Given this list of marker genes HIC1, RNASE10, BOK, RNF133, GADD45GIP1, POGK, ITGA6, APMAP, NAB2, WDHD1, MORN3, MGMT, MRPL11, RASSF7, RBBP8, NR2C2AP, ATP6V1C1, PIK3R2, RNPC3 (RNA binding region (RNP1, RRM) containing 3), GK, ALKBH3, GPR88, VPS25, CMSS1, FKBP3, STC2, HAPSTR1, CBR4, CHST6, B4GALNT1, FURIN, SLC35F3, CHML, ADARB1, THRAP3, RBIS, NDUFC2, HOOK2, PSMC4, DTX3, TFPI2, NDUFA9, COX10, CCT4, TNNT3, DCTN6, WNT8B, SDHAF1, GCNT2, ABRACL, SETD3, UNC13A, CHAMP1 (chromosome alignment maintaining phosphoprotein 1), NPHP1, PTTG1, POMT2, EID1, FAM72A, SGCB, CPD, DUS4L, KCTD14 (potassium channel tetramerization domain containing 14), FBXW8, ZNF490, UTP11, RBP1, MRM3, TRIM11 (tripartite motif containing 11), NDUFA7, IL1R2, CENPC, RNMT, MRI1, CIMIP4, CCDC172, SPEG, METAP1D, HTR5A, SVIP, THOC7, RHOB, EIF4G2, PARVG, MS4A13, UBE2E3, PDK1, ACSL4, UCHL1, ADGRA1, CALCOCO2, HNRNPA3, CCDC136, COX4I1, NRM, KPNA4, LTK, CCDC90B, PCM1, B3GALT6, TMEM14A, ADAM21, TTLL1, KPNB1, TNS1, PDHB, ACTL9, IL10, SRPRA, RPS25, HAT1, TSPYL1, GINS1, KHDRBS1, DNM1L, CARNMT1, MAPK10, UXT, MYBL1, OGDH, PPP2CA, TLK1, MICU2, SLC25A4, FGFR2, SIPA1L1, VPS37D, KCTD7, MDH1, GABRA3, MARCKS, TUBA4A, UBLCP1, MAOB, C1D, PLPP4 (NCBI Gene Id 196051), RBMS2, SEC24A, H2AC25, RGS12, POLR2B, SPAG1, ZNF354A, GABBR1, SFXN5, SLC35F1, OCIAD2, STT3B, MEGF10, POLR1D, GRIA2, TTC39A, NUP54, BCKDK, CUL4A, HNRNPK, SLC25A39, ADTRP, FRYL, ZNF239, SCARB1, ROR2, AFAP1L2, STX1A, CPTP, NAP1L1, B4GALT7, AOPEP (aminopeptidase O (putative)), GPX5, SOD2, COA6, E2F5, CELA1, SNX32, MID1, CH25H, MRPL22, MAPK8, THSD7B, MDM1, GGPS1, CLNS1A, DYNLL2, COX5A, STT3A, ASB3, TBCD, SNORD123, OLFM3, POLR1C, VWA8, POSTN, HNRNPR, B3GALNT1, VPS29, ZNF318, DNPEP, USP38 (ubiquitin specific peptidase 38), TOMM20, SLC9B2, SDC4, here is a description of the gene set: IL-10 or IL-6 stimulation of control 129xC57BL/6 murine bone marrow derived macrophages in the presence of LPS. We used microarrays to detail the global programme of gene expression changes in response to IL-6 or IL-10 stimulation in the presence of lipopolysaccharide. BMDMs were isolated from control, IL-6-/-, and IL-10-/- mice on a 129XBL/6 mixed background mice and differentiated in the presence of CSF-1 for 6-7 days. Cells were scraped and plated in 6 well plates at 2x10e6/well. Cells were washed with complete DMEM and rested for 1-2 hr before stimulation with combinations of IL-10 (10 ng/ml), IL-6 (2 ng/ml) or LPS (100 ng/ml) for 45 min or 180 mins. Complete biological replicates were performed. Human Gene Set: GSE5589_UNSTIM_VS_45MIN_LPS_AND_IL10_STIM_MACROPHAGE_DN from publication El Kasmi KC, Holst J, Coffre M, Mielke L, de Pauw A, Lhocine N, Smith AM, Rutschman R, Kaushal D, Shen Y, Suda T, Donnelly RP, Myers MG Jr, Alexander W, Vignali DA, Watowich SS, Ernst M, Hilton DJ, Murray PJ (PMID 17114459) studied in species Homo sapiens Genes down-regulated in bone marrow-derived macrophages: untreated (0 min) versus IL10 and LPS (45 min).